Given this list of marker genes BAX, LCK, CDKN2C, POLB, TCF3, here is a description of the gene set: Human Gene Set: KEGG_MEDICUS_PATHOGEN_HTLV_1_TAX_TO_E47_MEDIATED_TRANSCRIPTION species: Homo sapiens HTLV-1 Tax to E47-mediated transcription. Pathway ID: N00511. Pathway type: Pathogen. Pathway class: nt06160 Human T-cell leukemia virus 1 (HTLV-1). Pathway Definition from KEGG: TAX -| E47 => (POLB,LCK,BAX,CDKN2C)